Given this list of marker genes Nfe2, Taok1 (TAO kinase 1), Sox4, Dip2a, Cep295, Kat5, D1Pas1, Bmal1, Ep300, Arid5a, Klf15, Prkaa2, Park7, Prkaa1, Hint2, Xbp1, Hdac2, Ddx3x, Dip2b, Fam161a, Gsk3b, Pml, Sirt1, Sirt3, here is a description of the gene set: Mouse Gene Set: GOBP_REGULATION_OF_PROTEIN_ACETYLATION Any process that modulates the frequency, rate or extent of protein acetylation. species: Mus musculus